The following is a description of a gene set: species: Homo sapiens Reactome Pathway: Developmental Biology Developmental biology seeks to understand the array of processes by which a fertilized egg gives rise to the diverse tissues of the adult body. Examples of several developmental processes have been annotated here. In the early embryo, transcriptional regulation of pluripotent stem cells, gastrulation (including NODAL signaling), and activation of HOX genes during differentiation are annotated. Annotations of later, more specialized processes include nervous system development, cardiogenesis, aspects of the roles of cell adhesion molecules in axonal guidance and myogenesis, transcriptional regulation in pancreatic beta cells, adipogenesis, transcriptional regulation of granulopoeisis, transcriptional regulation of testis differentiation, LGI-ADAM interactions, and keratinization.<br><br>Transitions between cell types and cell states in developmental and differentiation processes are annotated as developmental cell lineages., and this is the list of marker genes: HNRNPU, CEACAM1, MEF2C, TFEB, SPTBN4, PKP1, KRT32, EPHB4, UBC, PAK5, HOXA3, RHOB, NCBP2, CACNA1H, PAX4, DPYSL5, EFNA5, SPTAN1, NPM2 (nucleophosmin/nucleoplasmin 2), RPL7, KAT2B, RPS17, NRCAM (neuronal cell adhesion molecule), FOXL2, CNOT11 (NCBI Gene Id 55571), GAB1, DSCAM, RPS6KA3, CDK2, BRCA1, TIAM1, LIPN, EIF4E, PRKCQ, KRTAP4-6, IARS1, DNM3, SPINK6, CXCR3, SEMA3E, DAND5, HDAC3, POU3F3, KRTAP24-1 (keratin associated protein 24-1), KRTAP10-1, KRT71, RPS6KA1, NR6A1, CDK4, TAL1, DICER1, UPF3A, EEF1E1, H2AC4, DMRT1, ROBO3.1, GSPT2, KRT12, BLNC1, KRTAP3-2, BCL7B, CSNK2A1, LAMB2, KRTAP12-3, UPF3B (UPF3B regulator of nonsense mediated mRNA decay), COL4A5, RPS4Y2, ADIPOQ (adiponectin, C1Q and collagen domain containing), NOTCH1, SCN7A, TP53, LAMC3, AGO3, DOK6, CREB1, LCE1F, SLIT3, PSMB1, TUT4, KRTAP5-8, MAF (NCBI Gene Id 4094), KRTAP5-6 (NCBI Gene Id 440023), KLK14, MAML2 (mastermind like transcriptional coactivator 2), CNOT3, PCDH19, MED6, MYH11, H2BC11, KLF13, RPL41, ABLIM2, MAMLD1, RAC1 (NCBI Gene Id 5879), ATP6V0E1 (NCBI Gene Id 8992), ROCK2, CNOT2, MYO5A, KLF5, SLIT1, AGRN, HSPA8, SMARCD3, MYL6, TSC22D1, TFE3, COL11A1 (NCBI Gene Id 317718), WNT11, ITGA1, KRTAP5-7, ELOB, LHX2, COL27A1, GATAD2A, TEAD1, RXRA, UNC5B, SMARCA2, KRTAP1-5, SHTN1, TUBA3D, ITGB1, KITLG, CNOT9, HNF4G, MED8, ABLIM1, EPHB2, NCAN (neurocan), MTA2, SPRR3 (NCBI Gene Id 6707, small proline rich protein 3), FOXO3, PIK3R3, KDM4C, PLXNA1, 28S rRNA, EPHA8, PKP3, ARHGAP35, HOXC4, MED23, KRTAP6-3, HHEX, KRT39, KRTAP1-1, MYH14, ANGPTL4, ZEB1, LGI1, MED20, ISL1, DLG3, POLR2A, CNTN1, MAP2K6, GPC1, BATF, H2AC18, CUL2, PAK2, MED1, PRM1, RPL36A, PI3, BIRC7, E2F1, USP33, ANK1, NOBOX, TUBB4A, DEK, ATP6V1H, PRNP, NFATC1, TUBB4B, ZSCAN10, BIRC5, TNRC6A, DOCK1, ARHGEF12, SUMO1, COL5A3, YWHAG, MYB, CAP2, RPS11, CDKN1A, KRTAP9-2, KDM5A, TGM5, PSMD8, COL4A1, SCN9A, KRTAP27-1, SIAH1, CELA2A, NTN1, TUBB3, GATAD2B, COL6A5, CSNK2A2, MCM5, LCE3D, KLK12, SPRR2E, ABL2, HEY2, LCE3A, MYRIP, ZFPM2, KRTAP5-4, CACNA1I, ACVR1C, TRPC6, FGF8, KRTAP10-3, AGAP2, SH3KBP1, DIS3L2, NCK1, SDC2, RPS29, CCNC, LEUTX, SS18L1, AKAP5, EPRS1, RING1, PERP, FOXA2, NOTO, SMARCE1, TUBAL3, TUBA4A, H3C15, MSGN1, CTNNA1, GSC, YWHAH, RPS20, H2BC21, PTPRC, FOXF1, SH3GL2, CEBPE, FURIN, EOMES, FGF10, HMGCR, CCNB1, CPEB1, HAND2, KRTAP26-1, LELP1, LEP, PSMB3 (proteasome 20S subunit beta 3), COL6A6, PML, SMARCD1, PIP5K1C, TFDP1, HDAC9, ALX3, CDH1, SCN11A (NCBI Gene Id 337933), ADAM11, POLR2D (RNA polymerase II subunit D), RELN, NRTN, COL4A2, EVL, PSMA1, MYO10, RARA, AMH, TNRC6C, KCNQ3, KRTAP19-5 (keratin associated protein 19-5), RPS27, JUP, COX7A1, RPL21, SHH, KRTAP5-2, RPL4, BCL7C, MYOCD, KRTAP10-8, LCE2D, COL9A3, ST8SIA4, SIX2, CACNA1D, PHC2, SMARCA4, KRT27, PRL, OTX2, KDM4B, GAB2, HOXA6, TRIO, GATA6, LCE1C, KRT8, PLXNA2, INS, HES7, KRT72, KRT6C, GATA4, PSMA7, AIMP2, RPLP0, GJB1, ARHGAP39, RPS16, H2AC20, DSP, KRT16, CCL3, RPS6KA2, DPF3, CEBPA, CLTCL1, TFAP2B, PFN1, RASA1, H2AC14, ADGRG6, POLR2C, KRTAP25-1, IL12RB2, TRPC1, KRTAP9-3, MEF2B, RPS19, SEMA5A, RPS18, NFATC2, LCE2C, PSMC3, RPL34, ZSCAN4, PABPC1, PAK6, PSMA6, GDNF, MED14, BOC (NCBI Gene Id 91653), KRTAP4-2, LAMA2 (laminin subunit alpha 2), SCN1B, TPRX2, UPF2, KRTAP5-1, MC3R, IL13, GDF1, PTK2, KALRN, SMAD4, NRAS, CTNNA2, RAP1GAP (NCBI Gene Id 9676), KRT7, ACVR2A, CLTC, SPTA1, BCL2, HOXA4, KRTAP13-1, NCAM1, KRTAP10-4, KRTAP4-8, RPLP1, ARPC3, COL1A1, BMP4, CXCR4, GBX2, H2AX, RPS6, CAPN1, KRT13 (NCBI Gene Id 3860), KAT5, RHOA, DEANR1, COL9A2, PIK3CD, SNAI2, LCE2A, EIF4A3, EIF4A2, 5S rRNA, SPI1, CNTN6, TUBA8, HDAC1, KRTAP6-2, CLDN7, KRTAP2-1 (NCBI Gene Id 81872), UCP1, GFRA4, THRAP3, SRGAP1, ROBO3, TBX20, PIK3CA (NCBI Gene Id 5290), CDSN, KRTAP21-2, TBX2, MESP1, RPL23A, RPS2, PPARA, NKX6-1, DSC3, SEMA3A, ARPC2, KRT85, TET2 (tet methylcytosine dioxygenase 2), SALL1, PSMC1, SHANK3 (NCBI Gene Id 85358), TREM2, ARID1B, ANK3, EBF1, EDNRB, GATA6-AS1, TGS1, MAG, PXDN, ZIC1, EGR2, MITF, PPARGC1A, LIPK, APH1A, MIR211, EPAS1, MED31, TFEC, JAG1, MAPK3, RPL24, COL6A2, GRIN1, DOK5 (NCBI Gene Id 87149), PRDM16, SOX2, ATP6V1F, KRTAP13-3, TRPC7, CASC3, EPHA5, SCMH1, COL9A1, EPHA6, PMEL, RPL32, SPRR2B, CASP14, MED13L, DRAP1, GMPR, KARS1, TRPC5, TGFA (transforming growth factor alpha), PSMD7, RBPJ, PLK1, PAIP1, POU5F1, IHH (NCBI Gene Id 50819), LYPLA2, ATP6V1D, KDM4E, CBX6, PSMB6, SCN10A, KAT2A, KDM6B, CFL1, KRT4, WASL, KRTAP9-1, HDAC11, KRT86, QARS1, MEN1, KRTAP19-1 (keratin associated protein 19-1), KRT40, AIMP1 (aminoacyl tRNA synthetase complex interacting multifunctional protein 1), HNF1B, TBL1XR1, RET, NEUROG3, HSP90AB1, SMAD3, COL11A2, H2AC6, CACNG2, CD72, AICDA, CSF3R, SPINK5, PSMD12, SPRR2D, NCOA3 (NCBI Gene Id 8202), LDB1, CACNG4, ZNF521, MED25, RPL3, RPL35A, H2AJ (NCBI Gene Id 83739), STAT5A, CTCF, CNTN2, MSX1, IRX1, UNC5D, LEF1 (NCBI Gene Id 51176), ACVR2B, KRT17, SIX1, MAML3, POLR2G, MED7 (NCBI Gene Id 9443), KPNA2, IL5, TCF7L2, ZSWIM8, KRTAP21-3, MSN, HJV, NGEF, CAPNS1, SCN5A, ITGA5, MYL9, TBL1X, POLR2J, CDK5R1, WNT1, METTL23, NKX2-5, PAIP2, NFASC, RBBP7, GAP43, DPPA4, KIT, AP2A1, LIG1, BNIP2, PSMC5, DLG4, HDAC5, RPS3A (NCBI Gene Id 6189), MLANA, ARPC4, RPL37, MED30, ELL2, RPL35 (NCBI Gene Id 92393), CSNK2B, TFDP2, KRT74, KRTAP13-2, ATP6V1A, FOXD3, ZP2, PRM2, HRAS, KRTAP2-2, ATP6V0C, TGM1, RPL10A, VAV3, SATB1, KIF4A, 5.8S rRNA, KRTAP10-2, PIK3R2, ADRM1, FOXH1, RPSA, GRB10, RPL10, ITGAV, RPS23, MED16, KRTAP19-4, MC5R, KCNQ2, EPHB1, CD24 (CD24 molecule), MESP2, RPL10L, NTN4, TUBA1C, FGFR1, DNM2, KRT79, HIRA, POMC, CDK8, PAK3, FAM120B, DKK1, DOK2, H2AZ2, TUBB2A, TRPC3, YAP1, CACNG8, EGF, USF1, MEF2A (NCBI Gene Id 4205), LGI3, ZEB2, WWTR1, KRT10, EPHA4, ST8SIA2, KRT15, ZNF335, KRTAP10-10, CLTB, TUBA1A (tubulin alpha 1a), TUBB8, POU3F2, PCSK6, SEMA7A, SMARCD2, RGMB, RPL30, HOXC11 (homeobox C11), MED17, SMARCC2, RANBP9, FOXO4, NR5A1, MAPK12, EFNB1 (ephrin B1), EZR, PSPN, MOV10, CDC42, GRB7, AP2M1, ARHGEF7, PKP4, ROCK1, RPL14, HDAC2, BCL7A, NCOA1, SRGAP3, H2AC7, PAX7, SPRR1A, KRT37, KRTAP9-4, COL24A1, CSF1, ZIC3, TBX21, KRT18, PAX3, KRTAP9-8, EIF4G1, KRTAP10-5, SCN2B, LAMA1, SOS2, FABP4, RPL29, COL4A4, MARS1, KRT6B, UNC5A, TUBB1, MYC, SNAI1, PSMC2 (NCBI Gene Id 5701), KRTAP5-11, PSMD2 (NCBI Gene Id 5708), PKLR, RPS4X, DLX5, RPL27A, CHD9, DRP2, RPL26L1, DOK1, DSC1, GRB2, COL6A1, KRT76, NCSTN, MED29, EFNA4, KDM5B, ATP6V0B, IRF4, DNM1, BTG4, AJUBA (NCBI Gene Id 84962), EFNA1, ELOVL3, MED18, STX1B, COL1A2, DPYSL4, MED27, POLR2K, LAMC1, MC1R, HOXB2, LAMA3, CNOT4, ABLIM3, KRTAP10-6, SRF, PSMB5, PPARG, CER1, ADAM22, KRT2, NKX2-2, ARPC5, RPS10, ARTN, KRTAP8-1, PRKACA, MYH10, ZNF638, WNT10B, ID4, MLPH, KRT78, KRAS, H2BC12, SPRR1B, KRTAP3-3, H2AB1, PRKCA (NCBI Gene Id 5578), KRTAP2-4, CXCL12, TYR, VASP, KRT6A, DIO2, KRTAP4-5, IL4, KRTAP19-6, DPY30, KRT14, ETS1, KRT3, RGMA, KRTAP2-3, LIPM, FAU, MMP9, TYRP1, CRIPTO3, PPL, PPP3CB, PFN2, GSPT1, TUBB2B, SIN3A, SLC2A2, CEBPD, NEO1, TBX6, PTPN11, LYN, LORICRIN, TPRXL, FOXP1, DUXB, PRDM14, ACTB, TCHH, KLF4, WFDC2 (WAP four-disulfide core domain 2), CBX8, FGF9, EDN3, MAPK1, NOTCH2, LHX4, KRT24, LCE3C, GFRA1, NR2F2, MED21, FRS2, MYF5, H1-8, LAMB1, RPL38, UNC5C, DSCAML1 (NCBI Gene Id 57453), PHC1, SRPK1 (NCBI Gene Id 6732), AKT1, KRT26, TNF, EGFR, DSG4, RPS28, DPPA3, UBA52, EPHA3, NEUROD1, GREM1, CDON, DAG1, XPO1, LCE1D, PITPNA, MMP2, RPL6, SPTBN2, KRT77, MYL12A, CFC1, KRT31 (NCBI Gene Id 3881), KRTAP19-3, SIRT1, LCE1B, RPL28, SCD5, DPF1, SRY, KRTAP3-1, LAMA5, TERT, SUZ12, PSMA4, STAT5B, DSG3, PSMA2, TCF7, MED11, MYOG, MEIS1, POU2F2, PXN, PDX1, MYF6, TRPM1, IAPP, PKNOX1, CNOT6L, SCN8A, POLR2E, RARB, PRKACB, LHX3 (NCBI Gene Id 8022), COL3A1, MED15, GXYLT2, KRTAP19-2, DPPA2, ATP6AP2, STPG4, ATP6V1C1, CSTA, ADAM23, EPHA1, GIT1, YWHAB, KRT38 (NCBI Gene Id 8687), MTA3, RPS21, EPHB3, SPRR2A, RPL18, ARPC1A, NAB2, PAX6, LGI4, ASAH1, RPS25, KRTAP9-9, TRIM33, ACTG1, LAMC2, ONECUT1, ATP6V1G1, TGFB1, COL2A1, UTRN, LEFTY2, COL5A2, PCGF2, KIF4B, CNOT8, ADGRV1, MAFA, CAP1, LIMK2, LAMA4, NUMB, RIPPLY2, SOX9, IVL, TUBA3C, CYP51A1, POLR2F (NCBI Gene Id 5435), KMT2D, HOXD11, DUX4, YWHAE, CIDEA, SMYD1, RPL39, VLDLR, KRT75, NAB1, HDAC6, KMT2C, KRTAP10-7, ATP6V0A1, PLXNC1, SERPINE1, POU3F1, HINT1, MED9, RNPS1, ACTR2, CLASP1, PSMD6, HOXB4, NODAL, LPL, LIPJ, CBFB, RPS26, RPL39L, HEY1, KAZN, BMP7, KRTAP23-1, PSMA3, LEFTY1, SREBF2, PRKACG, ROBO2, DUXA, KRTAP4-9, CCND3, ATP6V0E2, RUNX3 (NCBI Gene Id 864), GRIN2B, SOX1, RPL31, MAGOH, DLL3, HDAC8, DARS1, MAP2K1, H2BC4, TYROBP, HOXB3, SMARCB1 (SWI/SNF related, matrix associated, actin dependent regulator of chromatin, subfamily b, member 1), H2BC3, MYH9, SNW1, GSC-DT, RBBP5, MET, DPF2, MED24, TCF12, PRKAR2A, TBX1, ROBO1, COL6A3, H2BC17, ARHGEF28, KRTAP19-7, ST14, PPARGC1B, RPL17, CACNB1, CACNA1S, KRT1, TBPL2, PSMD13 (proteasome 26S subunit, non-ATPase 13), COL5A1, UBB, DCT, KRTAP19-8, EFNB2, DOK4 (NCBI Gene Id 55715), PSEN1, KRTAP5-5, PAK4, EFNA3, MYOD1, PLXNB3, H3-3A, PSMD11, BMI1, PAX8 (NCBI Gene Id 7849), SRC, NRP2, KRTAP4-7, RPS12, RPS14, RPS15A, SPRR2G, CNOT6, KRTAP20-2, PCK1, WNT4, KRTAP11-1, KRTAP10-11, RPS6KA6, KRTAP20-1, STX1A, AKT2, SCN3A, 18S rRNA, LGI2, CNOT10, CHD3, PHC3, RELA (NCBI Gene Id 5970), RPL13A, KRTAP12-1, KRTAP4-11, RPL26, AKT3, DLG1, HIF3A, CDKN2A, NCOA2, CHL1, SS18, POLR2I (RNA polymerase II subunit I), ANK2, SHC1, EP300, MAML1, KRT33B, ACVR1B, POLR2B, INSM1, PDLIM7, BCL2A1, LCE2B, TBX3, EED, MAFB, AGO1, TBX5, ACTR3, KRTAP29-1, MEF2D, RPS4Y1, MIXL1, CHD4, ABL1, HDAC10, PSMD3 (NCBI Gene Id 94019), HOXB1, KRT19 (keratin 19), KRT28, PSENEN, IRS2, NCOR1, PTF1A, RPL11, PTPRA, LHX9, FGF2, YY1, ARID1A, COL4A3, RPS27L, PMP22, SLIT2, GFRA3, RPL13, RPS13, KRTAP5-3, POU2F1, CDK19, SLC2A4, RAB27A, KRT33A (keratin 33A), OSR1, SEMA6D, EVPL, CBX2, POLR2H, UNG, EMX2, H2BC1, GCK, KLK13, SIAH2, AP2S1, SPTBN5, RPL18A (ribosomal protein L18a), RBX1, DIAPH1, EFNB3, VTN, ZNF423 (NCBI Gene Id 23090), ETF1, GSK3B, ID1, KRT23, PKP2, ARHGEF11, PSMD14, SCN4B, CNTNAP1, GATA3, PAGR1, RBBP4, JUN, RPS27A, RARS1, KRT80, PLCG1, SCN2A, HDAC4, LHX1, ATP6V1B2, EZH2, SOS1, KRT25, NCOR2, AP2A2, VAV2, MED12L, CDH4, KRT82, FLG, KRTAP22-1 (keratin associated protein 22-1), ELOC, RPL36, LAMB3, LCE6A, PLAC8, ENAH, RPL37A, RFX6, CNOT7, RHOC, CTNNB1 (NCBI Gene Id 1499), TUT7, PLXND1, TNKS1BP1, CACNA1G, SPAG9, NR5A2, SEMA4A, LCE3E, PAK1, MYL12B, RPS24, H2BC5, KRTAP16-1, H3C1, KRT36, LIN28A, HELZ2, EFNA2, H2BC15, EPHA2, ATP6V0D1, NOG, KRT81, WDR5, HOXD3, WNT3A, RPS6KA4, TCF3, TUBA4B (NCBI Gene Id 80086), KLK8, HSP90AA1, RUNX1, KRTAP5-9, PAXIP1, PSMC4, FARP2, KRT83, H2BC9, MED28 (mediator complex subunit 28), RPS6KA5, ACTL6A, RPL5, AREG, STAT3, PLXNA4, KRTAP4-4, RPTN, PTGDS, KRTAP1-4, DHH, SALL4, KRT73, RPS7, PSEN2 (NCBI Gene Id 5664), PIK3CB, STAT6, TCF4, FOXC1, KRTAP9-6, DSC2, KRTAP9-7, CACNB3, H2BC13, TBXT, ITGA8, MED4, TFAP2A, MC4R, KRT84, IRX2, MED10, GATA2, UBE2I (ubiquitin conjugating enzyme E2 I), SEM1, AP2B1, NCBP1, APH1B, RPS9, PSMA5, L1CAM, HOXA11, ITGB3 (NCBI Gene Id 3690), LCE1E, LCE3B, GFRA2, NANOG, CDC25B, SREBF1, HAND1, HDAC7, EDIL3, CACNB4, RPL8, MARK3, RPL22, KRTAP15-1, KMT2A, FGF7, SDCBP, DAB1, RAD50, KRTAP5-10 (keratin associated protein 5-10), EYA1, PSMB7, DPYSL3, RPS3, RPL19, ERBB2, FLI1, RRAS, AGO4, RPL12, KRTAP10-12, ALCAM, CACNG3, TET3, NTN3, RPL3L, ADIRF, EIF4A1, STT3B, PABPN1, YES1, SCN1A, RARG, KRT34, NPNT, CNOT1, H2BC14, CCND1, TEAD2, NELL2, GFI1, RNF2, RPL9, POLR2L, ITGA2, CDK5, KRTAP4-1, SPRR2F, KRTAP1-3, CARM1, FOXO1, KRTAP17-1, RPL36AL, IFNG, KRT9, HNF4A, MECOM, LARS1, KDM1B, PBX1, MPZ, EPHA7, EIF4B, TUBA3E, ITGA9, KRTAP6-1, KRT5, MED13, PABPN1L, SPTBN1, PLXNB1, KRTAP10-9, SOX10, YWHAZ, ZFP36L2, TNFSF11, KRTAP21-1 (keratin associated protein 21-1), MED12, IL4R, HOXD1, KRT20, SPINK9, RPS15, SEMA6A (semaphorin 6A), LCE1A, NCK2, MTA1, ONECUT3, LCE5A, ASH2L, PRSS8, TPRX1, ITGA10, SCN4A, HOXD4, WT1, SMARCC1, FOS, PLIN1, AGO2, RPL15, ZNF467, H4C1, DLL1, KLK5, UHRF1, DSG2, KDM6A, NCOA6, RBM8A, CACNB2, ITGA2B, ATP6V1E1, TUBA1B, PLXNA3, EBF2, EPHB6, PSMB4, SHC3, TRPC4, CRMP1, FN1, MED26, RPL22L1, LCE4A, PSMC6, RND1, SEMA4D, SYTL2, MYO9B, RPL7A, TLN1, SPTB, ITSN1, KRT35, IL6R (NCBI Gene Id 3570), CLTA, TEAD4, FGF4, PRX, ADAM10, DCC, RDX, SOX17, PAX2, MCM2, MBD3, SCN3B, PSMD1, FES, FOXA3 (NCBI Gene Id 3171), KRTAP12-4, HES1, MAP2K2, OCLN, TPST2, EPHA10, LFNG (NCBI Gene Id 3955), RPS8, STAT1, KRTAP4-3, ARPC1B, ZIC2, CRIPTO, EDN1, MAGOHB, CDX2, FOXA1, MAPK14, SRGAP2, GPR143, TFAP2C, CACNA1C, TCF7L1, CLASP2, TUBB8B, NRP1, CDH15, LIMK1, H2BC12L, SMAD1, MSI1, FYN, STAT4, SMAD2, FLRT3, RPS5, FOXC2, PIK3R1, MBP (NCBI Gene Id 4155), CBX4, CREBBP, TUBB6, KRTAP13-4, RPL23, CEBPB, RPL27 (NCBI Gene Id 6155), MED22, TNRC6B, H2BC26 (NCBI Gene Id 128312), KRTAP12-2, HOXA1 (NCBI Gene Id 3198), RPLP2, PSMB2, PADI6, DPYSL2, DSG1, CDH2, MAPK11, MED19, CD36, DCX, MAPK7, HNF1A, PIAS2, HOXA2, NFKB1, WNT9B